The following is a description of a gene set: studied in species Homo sapiens Pathway Definition from KEGG: IGF2* -> IGF1R -> GRB2 -> SOS -> RAS -> RAF -> MEK -> ERK IGF2-overexpression to RAS-ERK signaling pathway. Pathway ID: N00235. Pathway type: Variant. Pathway class: nt06263 Hepatocellular carcinoma. Human Gene Set: KEGG_MEDICUS_VARIANT_IGF2_OVEREXPRESSION_TO_RAS_ERK_SIGNALING_PATHWAY, and this is the list of marker genes: NRAS, SOS1, MAPK3, MAP2K2, IGF1R, MAP2K1, SOS2, KRAS, RAF1, BRAF, ARAF, HRAS, IGF2, GRB2, MAPK1